The following is a description of a gene set: Diseases of glycosylation, usually referred to as congenital disorders of glycosylation (CDG), are rare inherited disorders ascribing defects of nucleotide-sugar biosynthesis and transport, glycosyl transfer events and vesicular transport. Most CDGs cause neurological impairment ranging from severe psychomotor retardation to mild intellectual disability. Defects in N-glycosylation are the main cause of CDGs (Marquardt & Denecke 2003, Grunewald et al. 2002, Hennet 2012, Goreta et al. 2012) and can be identified by a characteristic abnormal isoelectric focusing profile of plasma transferrin. Disorders of O-glycosylation, glycosaminoglycan and glycolipid metabolism have recently been discovered and, together with N-glycosylation, represent the major pathways affected by glycan biosynthetic disorders. In addition, glycosylation diseases associated with the enzymes that mediate the biosynthesis of glycosylation precursors are described in this section. As the number of these disorders has increased, nomenclature has been simplified so that now, the name of the mutant gene is followed by the abbreviation CDG. Effective therapies for most types of CDGs are so far not available (Thiel & Korner 2013). Reactome Pathway: Diseases of glycosylation studied in species Homo sapiens part of: Diseases of metabolism, and this is the list of marker genes: ADAMTS10, PAPSS2, ADAMTS18, PRELP, DCN, KERA, DPM2, SDC3, MUC12, ADAMTS8, MPI, GALNT12, CHST14, LARGE1, NUS1, MUC6 (mucin 6, oligomeric mucus/gel-forming), BGN, ADAMTS7 (NCBI Gene Id 374629), NEU1, NOTCH1, PMM2, ADAMTS20, MUC5AC, SDC4, CHST3, ADAMTSL2, MUC17, MUC5B, CSPG5, ALG6, ADAMTS16, ALG3, EXT1, GNE, CFP, ST3GAL3, MUC15, CTSA, SPON2, SBSPON, OMD, ALG2, GPC3, ADAMTS17, DOLK, MOGS, FMOD, MUC20, B3GAT3, SDC1, MUC4, POMGNT1, MUC3A, ALG12, ADAMTS6, MUC1, THSD7A, B4GALT1, SRD5A3, AGRN, MGAT2, C1GALT1, HSPG2, SLC26A2, MAN1B1, POMT1, RFT1, THSD1, GLB1, ALG8, THSD4, DPAGT1, DPM1, VCAN, SEMA5A, GALT, GPC2, ACAN, CHSY1, B4GALT7, LFNG, OGN, GPC5, B3GALT6, GPC4, GALE, THSD7B (NCBI Gene Id 80731), GALNT3, MUC13, ALG11, ADAMTS13, B3GLCT, MUC7, ADAMTSL3, ADAMTS9, ALG14 (NCBI Gene Id 199857), MPDU1, ALG13, LUM, ADAMTSL1, POMT2, SDC2, GFPT1, ALG1, NOTCH2, ADAMTS15, CHST6, GALK1 (galactokinase 1), EXT2, DHDDS, MUC2, ADAMTS19, DAG1, ADAMTS2, SEMA5B, B4GAT1, HEXA, ADAMTS3, GPC6, MUC3B, BCAN, DPM3, MUC19, SSPOP, HEXB, PGM1, ADAMTS12, GPC1, ADAMTS14, NOTCH4, CSPG4, THBS1, ADAMTS1, C1GALT1C1, MUCL1, ADAMTSL5, MUC21, THBS2, NOTCH3, ADAMTS4, GALM, ADAMTS5, ADAMTSL4, SPON1, ALG9, NCAN, MUC16